The following is a description of a gene set: species: Mus musculus Mouse Gene Set: REACTOME_CHONDROITIN_SULFATE_DERMATAN_SULFATE_METABOLISM Chondroitin sulfate/dermatan sulfate metabolism, and this is the list of marker genes: Chsy1, B3gat2, Gpc4, Dcn, Chst7, Sdc3, Gpc5, Ust, Cspg4, Chst13, Chpf, Xylt1, Ids, Idua, Uxs1, Hyal3, Chst15, Gpc2, Arsb, Csgalnact2, Chst9 (carbohydrate sulfotransferase 9), Gpc1, Chst14, Chpf2, Gpc6, Chst3, B4galt7, Chsy3, Sdc4 (NCBI Gene Id 99320), Vcan, Bcan, B3galt6, Hexa, Xylt2, Hyal1, Chst11, Agrn, Cspg5, Sdc1, Hexb, Sdc2, Chst12, Dsel, Csgalnact1, B3gat3, Gpc3, B3gat1, Bgn, Dse